The following is a description of a gene set: studied in species Homo sapiens Abnormal corneal epithelium morphology Human Gene Set: HP_ABNORMAL_CORNEAL_EPITHELIUM_MORPHOLOGY Abnormality of the corneal epithelium, that is of the epithelial tissue that covers the front of the cornea., and this is the list of marker genes: ZMPSTE24, SLC39A4, HLA-DRB1, WAS, HLA-DPA1 (major histocompatibility complex, class II, DP alpha 1), ERCC4, FOXC2, NLRP3, TWIST2, TLR4, CTLA4, UROD, ERCC5, CCR1, MBTPS2, FOXC1, KLRC4, TAT, ATP2A2, ZNF469, HLCS, DDB2, MAB21L1, PRDM5, DNMT3B (NCBI Gene Id 1789), ERAP1, AAAS, ZFX, TRAPPC11, IFNGR1 (NCBI Gene Id 3459), GATA1, TP63, FRG1, NGLY1, PNPLA1, TGFBI, ZEB1, PAX6, IL6ST, SPINT2, CRLF1, PRTN3, CARS1, SCN9A, TGM1, AEBP1, FBN1, MEFV, NTRK1, PLEC, COL4A5, RIPK4, ERCC2, NIPAL4, RNF125, MMP1, FAS, PTPN22, GSN, STAT4, GJB2, TRIM44, CLTCL1, TARS1, KIFBP, ALOX12B, COL7A1, XPA, WIPF1, IKBKG, SULT2B1, LYZ, KRT3, PERCC1, COL17A1, GJB6, ALDH3A2, IL12A, ERCC6, ERCC3, DUX4, UROS, IL12A-AS1, FGFR3, EPCAM, COL4A6, IARS2 (isoleucyl-tRNA synthetase 2, mitochondrial), GTF2H5, MTTP, CERS3, NLRP1, WT1, IL10, ELP1, FGF10 (NCBI Gene Id 2255), ALOXE3, RNF113A, FGFR2, PLCG2, PRDM12, LBR, AARS1, IKZF1, ABCA12, CTNS, COL4A4, SLC35C1, DUX4L1, DCN, IL23R, SREBF1, C4A, UBAC2, HLA-B, GMPPA, RECQL, SDR9C7, FERMT1, BTNL2 (butyrophilin like 2), AIRE, NOD2, MPV17, LMNA, XPC, GTF2E2, CHST6, MPLKIP, HLA-DPB1, SMCHD1, POLH, ERCC8